The following is a description of a gene set: species: Mus musculus A signal transduction process that contributes to a mitotic DNA replication checkpoint. Mouse Gene Set: GOBP_MITOTIC_DNA_REPLICATION_CHECKPOINT_SIGNALING, and this is the list of marker genes: Topbp1, Cdc6, Donson, Nae1, Hus1b, Ticrr, Hus1, Rad17, Clspn, Orc1, Zfp830